The following is a description of a gene set: from publication Chen Y, Wang X (PMID 31504780) Genes predicted to be targets of miRBase v22 microRNA hsa-miR-4742-5p in miRDB v6.0 with MirTarget v4 prediction scores > 80 (high confidence targets). Human Gene Set: MIR4742_5P species: Homo sapiens, and this is the list of marker genes: PSME4, SNURF, ATP11C, SSBP2, KSR2, ACTR1B, RNFT2, CLTC, ACBD5, BIN1, CEP41, CDC42EP4, GLCCI1, TBC1D28, PCSK7, IMPA1, MORC3, ESR1, STOX2, SPECC1L, AZI2, ESCO2, NFIX, SYT1, CREB5, EGF, CCL5, PRIMPOL, THOC2, LSM11, DGCR2, RIMKLA, AMMECR1L, ENO4, AP3S1, FJX1, ARHGAP28, PYHIN1, CYRIA, GLRX5, GRSF1, ST3GAL6, XPO4, FUT6, ITPRID1, RB1CC1, SEMA4F, PHF2, NSF, RSBN1, PRR14L, PRLR, SORBS2, PARP11, PRKAA2, UGGT1, OPRK1, CRIM1, SHLD2, TNPO1, DOLPP1, SV2B, CCDC152, SLC39A10, PHKA1, EGR1, FOXO1, RC3H1, SLC8A2, VGLL4, PDE4B, IRS2, CHL1, STRN, CTTNBP2NL, EMCN, SEMA3A, JMJD1C, MAFB, HERC1, LRRC8C, OTUD7A, OIP5, SERINC5, NKIRAS1, DNAJA2, FAM200B, SKI, USP3, TARDBP, ZNF365, ACTR1A, GPR63, MBD2, ERGIC2, PPP4R4, ZNF608, SNRPN, MAP2K4 (mitogen-activated protein kinase kinase 4), LEF1, FAM218A, INSR, TACC1, PRKAR2A, LDB3, IER3IP1, CYB561D1, AK2, RNF123, SEC14L5, LOXL4, U2SURP, EIF3J, HMGN3, GPAM, ATG5, BNC2, AMER3, GLIPR1L1, SLC16A14, TSHZ2, GPR37L1, RMND5A, CRACDL, TNFSF14, SOX6, BSDC1, MAN2A1, ANKRD18A, RPF2, STAG2 (NCBI Gene Id 10735), CREB1 (NCBI Gene Id 1385), LPP, PCDHB13 (protocadherin beta 13), TM2D3, ZBTB20, SREK1, FBXO8, NBPF11, MAP2, FAM133B, NAV1, RAB1A, HKDC1, EPM2AIP1, BTBD3, ZNF652, SLAIN1, MIEF1, DENND1B, FOXC1, UBP1, DCLK1, MINDY2, CRPPA, RABGAP1L, NDUFA6, SH3BGRL2 (SH3 domain binding glutamate rich protein like 2), CSDE1, INO80D, NMT2, YY1, CCDC117, COL21A1, ORC5, MCTP2, TFDP1, HTR2A, BRD8, PLXDC2, SEC61G, FBXW7, HINT1, TAX1BP3, PDGFB, ZPLD1, CACNA1B, ATXN7, MKRN3